The following is a description of a gene set: part of: p75NTR regulates axonogenesis studied in species Mus musculus electronically inferred by orthology from the curated human pathway This event has been computationally inferred from an event that has been demonstrated in another species.<p>The inference is based on the homology mapping from PANTHER. Briefly, reactions for which all involved PhysicalEntities (in input, output and catalyst) have a mapped orthologue/paralogue (for complexes at least 75% of components must have a mapping) are inferred to the other species. Reactome Pathway: Axonal growth inhibition (RHOA activation), and this is the list of marker genes: Lingo1, Mag, Omg, Ngfr, Rtn4